The following is a description of a gene set: Partial dislocation of the head of the radius. studied in species Homo sapiens Human Gene Set: HP_RADIAL_HEAD_SUBLUXATION Radial head subluxation, and this is the list of marker genes: CHD7, GLI3, XYLT1, KIF22, B3GALT6, HNRNPH1, BPNT2, DCHS1